Given this list of marker genes COL18A1, CHRNG, CCBE1, CREBBP, NSUN2, IRF6 (NCBI Gene Id 7452), CUL7, RUNX2 (NCBI Gene Id 860), CDK13, MESP2, COLEC11, ARID1B, LIMK1, WBP11, POLA1, FLNA (NCBI Gene Id 8272), GTF2IRD2, EP300, CCL2, TBC1D24, HES7, FUZ, LIG4, BICD2, IKBKG, CLIP2, KCNH1 (NCBI Gene Id 8656), SALL4, RAF1, MYH3, ATP6V1B2, CCNQ, TBX6, RPS19, GDF6, ZIC1, MASP1, TMEM270, DLL3, RIPPLY2, HMX1, MAFB, MEOX1, ACTB, BMP2, FKBP6, B3GLCT, NCF1, BUD23, DNAJC30, MAP3K7, VPS37D, TBXT, FIBP, PTPN11, NEK9, RFC2, COLEC10, DARS1, RAB23, FLNB, STX1A, GTF2IRD1, PUF60, TBL2, TNXB, GDF3, METTL27, VANGL1, ELN, EBF3, PORCN, DACT1, VANGL2, LFNG, RECQL4 (NCBI Gene Id 9401), GTF2I, RORA, CHN1, EIF4H, AMER1, BAZ1B, NOTCH2NLC, PTDSS1, BRAF, here is a description of the gene set: studied in species Homo sapiens Spina bifida occulta The closed form of spina bifida with incomplete closure of a vertebral body with intact overlying skin. Human Gene Set: HP_SPINA_BIFIDA_OCCULTA